Given this list of marker genes PDGFRA, here is a description of the gene set: Sunitinib is a class II TKI that is often used as a second-line treatment in PDGFR- and KIT-driven cancers that develop resistance to imatinib. Sunintib is approved for the treatment of renal cell carcinoma, GIST and pancreatic tumors. A number of PDGFR mutations exhibit resistance to inhibition by sunitinib. part of: Drug resistance of PDGFR mutants Reactome Pathway: Sunitinib-resistant PDGFR mutants studied in species Homo sapiens